Given this list of marker genes ELF4, PSMB8, PSMB9, PTPN22, FAS, HLA-B (NCBI Gene Id 730410), STX11, POLA1, STAT4, NR1H4, ABCB11, HMOX1, CBLB, HLA-DRB1, PLCG1, CASP10, CD247, MEFV, FASLG, IL2RA, IL6R, PTPN6, ABCB4, ANKRD55, UNC13D, PRF1, PTPN2, STXBP2, SASH3, CARD10, FADD, SP110, LYN, IL2RB, P4HA2, IL12RB1, ATP8B1, here is a description of the gene set: Human Gene Set: HP_ABNORMAL_CIRCULATING_INTERLEUKIN_CONCENTRATION studied in species Homo sapiens The concentration of an interleukin (a class of cytokines) is outside the limits of normal. Abnormal circulating interleukin concentration